Given this list of marker genes CHD7, TACR3, ANOS1, CYP19A1, GNRH1, GNRHR (gonadotropin releasing hormone receptor), DUSP6, WDR11, PROK2, FGFR1, FGF8, KISS1, ESR2, HS6ST1, NHLH2, SPRY4, FGF17, TAC3 (tachykinin precursor 3), KISS1R, PROKR2, TUBB4A, NSMF, here is a description of the gene set: Human Gene Set: HP_EUNUCHOID_HABITUS A body habitus that is tall, slim and underweight, with long legs and long arms (i.e., arm span exceeds height by 5 cm or more). Eunuchoid habitus species: Homo sapiens